The following is a description of a gene set: The process whose specific outcome is the progression of the optic nerve over time, from its formation to the mature structure. The sensory optic nerve originates from the bipolar cells of the retina and conducts visual information to the brainstem. The optic nerve exits the back of the eye in the orbit, enters the optic canal, and enters the central nervous system at the optic chiasm (crossing) where the nerve fibers become the optic tract just prior to entering the hindbrain. studied in species Homo sapiens Human Gene Set: GOBP_OPTIC_NERVE_DEVELOPMENT, and this is the list of marker genes: PAX2, TMEM126A, LPAR1, NDP, EPHB1, CHRNB2, NKX2-2 (NK2 homeobox 2), KCNC1, EPHB2 (NCBI Gene Id 50980), KCNA2, TCIRG1, RPL24, NAV2, GLI3, ATOH7, SLC38A8, EXT1, SLC25A46, KCNC2